The following is a description of a gene set: Human Gene Set: HP_CYSTINURIA An increased concentration of cystine in the urine. Cystinuria studied in species Homo sapiens, and this is the list of marker genes: PPM1B, AASS, SLC7A9, PREPL, SLC3A1, CAMKMT